The following is a description of a gene set: studied in species Homo sapiens from publication Lund R, Aittokallio T, Nevalainen O, Lahesmaa R (PMID 14607935) Th1 and Th2 cells arise from a common precursor cell in response to triggering through the TCR and cytokine receptors for IL-12 or IL-4. This leads to activation of complex signaling pathways, which are not known in detail. Disturbances in the balance between type 1 and type 2 responses can lead to certain immune-mediated diseases. Thus, it is important to understand how Th1 and Th2 cells are generated. To clarify the mechanisms as to how IL-12 and IL-4 induce Th1 and Th2 differentiation and how TGF-beta can inhibit this process, we have used oligonucleotide arrays to examine the early polarization of Th1 and Th2 cells in the presence and absence of TGF-beta after 0, 2, 6 and 48 hours of polarization. Human Gene Set: GSE2770_UNTREATED_VS_IL4_TREATED_ACT_CD4_TCELL_48H_DN Genes down-regulated in CD4 T cells: untreated (0h) versus activated by anti-CD3 and anti-CD28 and then stimulated by IL4 (48h)., and this is the list of marker genes: PINX1 (NCBI Gene Id 91819), TIMM23, CCDC124, PPIL1, SEC13, SLAMF7, DPP3, COMMD5, CKS2 (NCBI Gene Id 1164), ATP5MG, PIH1D1, FOXM1, ITGB3, CCDC34, DDX19A, RECQL4, CDC16, RBKS, MYB, MTBP, CHTF18, CKAP2, TUBG1, MYBL2 (MYB proto-oncogene like 2), DMWD, MEMO1, SUDS3, TIPIN, UBE2M, MIS18A, LRWD1, ZC3H14, TSTD2, IFT80, LRP8, VPS35, CDC45, GINS2, SERINC5, OIP5, NOA1, TTC9C, GRSF1, BAG2, KIF20B, NME7, UBE2T, CDKN2C, NAF1, MRPL27, TG, TKTL1, PNLDC1, SAPCD2, PCYT2, SMCO4 (NCBI Gene Id 56935), RAD51B, POLR3H, OPTN, ANP32B, ROPN1L, DERL3, PIPOX, TEDC1, HBG2, CFAP298, C3orf38, BRIP1, NSDHL, AK3, APOO, FADS2, MTHFD1L, PDK3, PCYT1B, NSMCE4A, PNO1, CAPRIN1, KRT222, SPATA24, MBD4, FAS, GINS1 (GINS complex subunit 1), SLC25A6 (solute carrier family 25 member 6), HMGN5, RELN, ARHGAP29, PIMREG, RCC1, GMDS (GDP-mannose 4,6-dehydratase), CENPM, TICRR, IQGAP3, TOPBP1, SNX1, MTMR9, CENPF, CEP72, ATP5PB (NCBI Gene Id 515), NBN, SPI1, LAGE3, MTM1, IDH3A (isocitrate dehydrogenase (NAD(+)) 3 catalytic subunit alpha), NSMCE2, ESPL1, CPSF2, FAM98B, ATAD1, SAE1, CCNH, CNPY2, CFAP36, ADK, ST3GAL5, BUB1B, PRPS2 (NCBI Gene Id 5634), FAM117A, PKP4, SLC25A11, NUTF2, B9D1, UCHL5, PARP8, NEK2, ETHE1, MND1, TAF9, PA2G4, CENPN, DYNLL2, EFCAB11, CNOT9, PPP1R8, PLPP5, MSRA, PRADC1, CIP2A, PREP, SPEF1, MRPL10, DBF4, TRAIP (TRAF interacting protein), TBC1D31, SLC25A13, DAB2IP, SLC15A3, COX6B1, DHFR, SELENOH, CDC25B, UBE2E1, CFAP251, MCUB, MRPS14, SSX2IP, GTF2A2, BACH2, C3orf70, SCCPDH, TMEM201, IFT122, SOX5, OTUD6B, XRCC3, RAPGEF3, SSR1, SCAF11, THOC7, CISD1, THBD, DDX28, ERI1, DSN1, NDUFA8, CDC42EP3, KNL1, IMMT, CDKN2A, APOC2, CRELD2, NEDD8, ACYP2, TTK, HADHA, RAD18, MED8 (mediator complex subunit 8), H2AX, PRPF40A, TERF2IP, HES6, MRPL44, PRDX4, DHX40, ATP5PF, GALC, TXNL1, TMED6, TSG101